Given this list of marker genes IGF2BP3, GXYLT2, SPOCK1, COL10A1, EPHA4, COL11A1, BCAT1, AMIGO2, ST3GAL1, CDK14, CTHRC1, GNB4, MSR1, UBE2QL1, TMEM45A, SNHG33, CRISPLD1, AKT3, COL4A1, SFRP4, GPC6, TIMP3, FBN1, BICD1, SFMBT2, VSIG10L, NREP, PRELP, FKBP14, GIGYF2, IL1RAP, MGP, PALM2AKAP2, ALDH1L2, TAFA5, RIMKLB, RAB31, FBXO32, LOX, CCDC88A, IL6, EFEMP1, CDH11, GPNMB, ANOS1, TRPC1, CARMN, TLR2, MAP3K4-AS1, CMTM3, IER5L, CEP170 (centrosomal protein 170), SLC1A3, RBMS1, DSE, THBS4, COL1A2, THBS2, MIR1245A, DAB2, USP51, TRIM6, IGFBP3, MTCL1, NOX4, BMPR1B, GDAP1, DDR2, TMEM132A, MOXD1, NID2, SNAI2, ZNF423, WNT2, PGBD1, FMO2, SNX10, COL12A1, MAFB, TIAM1, ADAM12, FSTL1, RARRES1, SFRP2, STC2 (stanniocalcin 2), SOD2, ANTXR1, PCED1B, LPL, PLA2G7, ANGPT2, FRMD6, CEMIP, COL8A1, ITGBL1 (integrin subunit beta like 1), GSDME, SEPTIN11, LAMA2, COL5A2, IL24, TPRG1, PRDM6, CHST11, GAS1, ARL4C, TNFAIP6, GUCY1A1, BCL6, FNDC1, ADAMTS12, WWTR1, LINC01614, HEY1, QKI, PLOD2, PLXDC2, ISM1, EDNRA, SLC5A3 (NCBI Gene Id 6526), PDGFC, CPNE8, CD163, GLIS2, PDE3A, FAP, MAGEH1, NUAK1, FN1, COL15A1, VCAN, TWIST1, AXL, CYP1B1, ARMCX1, NXN, NIPBL, CALD1, ACTL8, EGFL6, MYH10 (NCBI Gene Id 4628), SOHLH2, INHBA, LTBP2, C3AR1, HES2, PLAU, JMY, CYP7B1, PIK3R5, CCN4, CDH6, PRRX1, RNF213, SALL4, SLIT2, ALOX5, IBSP, ESM1, ADAMTS2, SPP1, SPARC, SLC2A3, NTM, GFPT2, CPE, AUTS2, MMP11, ZNF532, THBS1, APOC1, HDGFL3 (NCBI Gene Id 50810), CST4, CAV2, BGN, HLA-DQB1, SULF1, HAVCR2, here is a description of the gene set: Human Gene Set: VECCHI_GASTRIC_CANCER_ADVANCED_VS_EARLY_UP Up-regulated genes distinguishing between two subtypes of gastric cancer: advanced (AGC) and early (EGC). Gastric carcinoma is one of the major causes of cancer mortality worldwide. Early detection results in excellent prognosis for patients with early cancer (EGC), whereas the prognosis of advanced cancer (AGC) patients remains poor. It is not clear whether EGC and AGC are molecularly distinct, and whether they represent progressive stages of the same tumor or different entities ab initio. Gene expression profiles of EGC and AGC were determined by Affymetrix technology and quantitative polymerase chain reaction. Representative regulated genes were further analysed by in situ hybridization (ISH) on tissue microarrays. Expression analysis allowed the identification of a signature that differentiates AGC from EGC. In addition, comparison with normal gastric mucosa indicated that the majority of alterations associated with EGC are retained in AGC, and that further expression changes mark the transition from EGC to AGC. Finally, ISH analysis showed that representative genes, differentially expressed in the invasive areas of EGC and AGC, are not differentially expressed in the non-invasive areas of the same tumors. Our data are more directly compatible with a progression model of gastric carcinogenesis, whereby EGC and AGC may represent different molecular stages of the same tumor. Finally, the identification of an AGC-specific signature might help devising novel therapeutic strategies for advanced gastric cancer. species: Homo sapiens from publication Vecchi M, Nuciforo P, Romagnoli S, Confalonieri S, Pellegrini C, Serio G, Quarto M, Capra M, Roviaro GC, Contessini Avesani E, Corsi C, Coggi G, Di Fiore PP, Bosari S (PMID 17297478)